The following is a description of a gene set: Human Gene Set: MIR6769B_5P studied in species Homo sapiens Genes predicted to be targets of miRBase v22 microRNA hsa-miR-6769b-5p in miRDB v6.0 with MirTarget v4 prediction scores > 80 (high confidence targets). from publication Chen Y, Wang X (PMID 31504780), and this is the list of marker genes: CLEC12B, SYT7, ABI3BP, SYNGAP1 (NCBI Gene Id 8831), ZBTB4 (zinc finger and BTB domain containing 4), POLR3H, SIGLEC8, SOBP, RNASE13, HOXB9, KCNA3, IGF1, MIF4GD, SLC6A11, ATXN1, CCDC146, YWHAH, B9D1, RUSC1, ZNF275, INO80D, LIG3, RIPK2, PBX3, ATP11A, ZDHHC21, L1CAM, CACNA2D2, BCL7A, GNAS, GABRP (gamma-aminobutyric acid type A receptor subunit pi), BCAN, CLTRN, B4GALT5, PTPRN, TMEM178B, CACNA1A, EDAR (ectodysplasin A receptor), HDHD2, GLE1, CACNA1E, ANTXR2, SRR, GRIA4, AP1M1, LRFN2, MAGI3, OBP2B, VWA8, LENEP, TGM2, STMN2 (NCBI Gene Id 11075), SLC6A8, CDC5L, SCN1B, ATP1B2, COL4A5, CACUL1, MAPRE2 (microtubule associated protein RP/EB family member 2), SOD3, GALNT16, PHKG2 (NCBI Gene Id 5261), SHOX2, SNAPC5, TMEM132E, CNTFR, RBM38, ROGDI, ZHX3, GRIN3A, CDHR1, MLLT6, HAPSTR1, RAPGEF2, PAPPA2, TSNARE1, RSPO4, ZBTB7A